The following is a description of a gene set: Mouse Gene Set: JMJD1C_TARGET_GENES species: Mus musculus Genes containing one or more binding sites for (Jmjd1c) in their promoter regions (TSS -1000,+100 bp) as identified by GTRD version 20.06 ChIP-seq harmonization. from publication Yevshin I, Sharipov R, Kolmykov S, Kondrakhin Y, Kolpakov F (PMID 30445619), and this is the list of marker genes: Gm5129, Dhrs11, Nrbp1, Mir1907, Unc50, Rpl41, Ino80c (NCBI Gene Id 225280), Oscp1, Txnl4b, Lrig1, Ccdc160, Cdr2l, Zfp11, Lrrc18, Dgki, Gm16876, Gdf9, Mzt2, Gnao1, Bbox1, Pipox, Map1a, Vrk3, Ctsa, Gm3510, Tedc2, Ubr5, Arl5b, Leprot, Kirrel3, Dab2, Pcdh7, Pik3r1, Nynrin, Tmem147os, Tcea2, Pla2g15, Trps1, 1500002C15Rik, Epb41l2, Pigb, Hmox1, Toe1, Fam110b, Llph, Kit, Erbb4, Axin2, Papolg (poly(A) polymerase gamma), Arrb2, Nat2 (N-acetyltransferase 2 (arylamine N-acetyltransferase)), Adpgk, Igdcc4, Slx4ip, Pcdhgc3, Dnm1l, Slc6a9, Phip, Tbc1d8b, Pus3, Gm3764, 5930420M18Rik, Crip2 (cysteine rich protein 2), Pramel12, 2310014F06Rik, Cacna2d1, Usp20, Disp2, Acot7, Gm7626, Sfpq, Zfp473, Zfp715, Akap10, Gm10433, 1500015L24Rik, Serpine2, Gm4925, Dok7, Mir574, Plac1, Cr2, Gm4876, Exosc3, Gm17057, Mief1, Gm15997, Dhx38, Rlbp1, Wnt5a, Kti12 (KTI12 homolog, chromatin associated), Tmod2, Dnaja3, Tcf12, Tmem147, Dglucy, Ccdc141, Atoh8, Syngr1 (synaptogyrin 1), Mdc1, Mogat1, Map3k10, Caprin1, Gm11679, Ung, Ltbp1, Fam114a1, Mir191, Tmem64, Gm10398, Cuedc2, Gm15742, Hspa1b, Trex1, Mirlet7b, Pigbos1, Xrcc5, Mrpl52 (mitochondrial ribosomal protein L52), Thtpa, Haus4, Hmbs, Endod1, Alg2, Vapa, Pou2f1, C2cd3, Enpp3, Rgs3, Coq10b, Kdm4c, Rsl24d1, 1700039M10Rik (NCBI Gene Id 67518), Manbal, Anp32a, Gm16008, Ccdc13, Dusp23, Rsad2, Gin1, Fbxo5, Gm14051, Kdr, Pcolce, Fgd4, Txnip, Zfp521 (zinc finger protein 521), Tbc1d10b, Nufip2, Gpx1, Nol4l, Gm15831, Nme6, Bcas1, Pi4k2a, Lbx1, Wwc1, 2700062C07Rik, Msl3l2, 9630013D21Rik, Coro1c, Sdf2, 4833445I07Rik, Tmcc2, Pde4dip, Trak1, Ikbkg, Rnd3, St3gal2, Lcmt1, Mutyh, Ndufs4, Mia2, Tbc1d20, Tmem185b, Sap130, Mtss2, Klhl15, Prdm4, Pkia, Zfp146, Appl2, Ckap5, Rfc1, Tceal8, Chd3, Gm15172, Fancl, 1110002L01Rik, Kcnip3, Ppp1r15a, Mdfic, Atg4a, Arhgef17, Tspoap1 (TSPO associated protein 1), Zfp595 (NCBI Gene Id 218314), Clasp1, D730045B01Rik, Pde4d, Esr1, Ank2, Tefm, Plcl1, Pafah1b2 (platelet-activating factor acetylhydrolase, isoform 1b, subunit 2), Pml, M6pr, 1700088E04Rik, Zfp106, Asxl2, D630024D03Rik, Nom1, Mir670hg, Fgf1, Nfe2l1, Sncaip, Sh2b1, Gdpd1, Pde4b, Cttn, Ddx25, Defb42, Rab11a, Coa5, Tex30, H3c4, Arhgef2, Sepsecs (Sep (O-phosphoserine) tRNA:Sec (selenocysteine) tRNA synthase), Tmed1, 3100003L05Rik, Dock10, Lrrc61, Fktn, Gm15441, Tmcc1, Arl1, Mir1904, Celrr, Abcb6, Pmm2, Dgkd, Aff1, Dph3, Gss, Fbxo38, Shoc2, Camk2b, 9330179D12Rik, Ptp4a3, C3, Mkks, Abhd17b, Slc22a5, Zfp462, Vldlr, Irgm1, Capn10, Tcf4, Slc2a4, Net1, Nwd1, Eif5a, Zfp874b, Tmem176a, Clock, 4930502E09Rik, Gm16576, Scmh1, Mynn, BC005624, Mcm2, 3000002C10Rik, Tet1, B230317F23Rik, Fkbp15, 1700054K19Rik, Ankrd17, Gas7, Ets1, Mx2, Zfp101, 2810029C07Rik (NCBI Gene Id 72670), Smim11, Ndor1, Runx1, H4c14, Cacng2, Ndufaf3, Jarid2, Nuak2, Mir423, Isca1, Plekha8 (NCBI Gene Id 231999, pleckstrin homology domain containing, family A (phosphoinositide binding specific) member 8), Sec61b, Serpina3n, Inppl1, Pnpt1, Arhgef11, Mir9-2hg, Mtif2, Hmga2, Tle4, Gm30270, Sparc (secreted acidic cysteine rich glycoprotein), Mtmr2, Palmd, Npc1, Ccdc12 (NCBI Gene Id 97506), Hltf, Xbp1, U2af1, Supt6, Atad1, Tnpo3, 4930447M23Rik, Rapgef4, Pyroxd1, Cadps, Fan1, Irag2, 1110059E24Rik, B2m, Nsrp1, Trmt1, Gm12925, Sez6l, Use1, Gm40117, Tnpo1, Zfp408, Gm2164, Dnajb6, Med25